Given this list of marker genes PIK3CG, PIK3CD, PIK3R2, PIK3C2A, PIK3C2B, CCKBR (cholecystokinin B receptor), PIK3C2G, ATM, PIK3R6, PIK3CB, PIK3R1, PIK3R5, PIK3R3, PIK3C3, PIK3CA, here is a description of the gene set: studied in species Homo sapiens Human Gene Set: GOMF_1_PHOSPHATIDYLINOSITOL_3_KINASE_ACTIVITY Catalysis of the reaction: a 1-phosphatidyl-1D-myo-inositol + ATP = a 1-phosphatidyl-1D-myo-inositol 3-phosphate + ADP + H+.